Given this list of marker genes VDR, CYP11A1, BMAL1, CYP19A1, DHCR24, STAR, NR5A2, here is a description of the gene set: from publication Matzuk MM, Lamb DJ (PMID 18989307) studied in species Homo sapiens Reproduction is required for the survival of all mammalian species, and thousands of essential 'sex' genes are conserved through evolution. Basic research helps to define these genes and the mechanisms responsible for the development, function and regulation of the male and female reproductive systems. However, many infertile couples continue to be labeled with the diagnosis of idiopathic infertility or given descriptive diagnoses that do not provide a cause for their defect. For other individuals with a known etiology, effective cures are lacking, although their infertility is often bypassed with assisted reproductive technologies (ART), some accompanied by safety or ethical concerns. Certainly, progress in the field of reproduction has been realized in the twenty-first century with advances in the understanding of the regulation of fertility, with the production of over 400 mutant mouse models with a reproductive phenotype and with the promise of regenerative gonadal stem cells. Indeed, the past six years have witnessed a virtual explosion in the identification of gene mutations or polymorphisms that cause or are linked to human infertility. Translation of these findings to the clinic remains slow, however, as do new methods to diagnose and treat infertile couples. Additionally, new approaches to contraception remain elusive. Nevertheless, the basic and clinical advances in the understanding of the molecular controls of reproduction are impressive and will ultimately improve patient care. Human Gene Set: MATZUK_STEROIDOGENESIS Genes important for steroidogenesis, based on mouse models with female fertility defects.